The following is a description of a gene set: species: Homo sapiens Binding to an ankyrin repeat of a protein. Ankyrin repeats are tandemly repeated modules of about 33 amino acids; each repeat folds into a helix-loop-helix structure with a beta-hairpin/loop region projecting out from the helices at a 90-degree angle, and repeats stack to form an L-shaped structure. Human Gene Set: GOMF_ANKYRIN_REPEAT_BINDING, and this is the list of marker genes: SHANK1, KIF21A, HIF1AN, TERF1, TNKS1BP1, RELA, OAZ3